The following is a description of a gene set: Interleukin-2 receptor (IL-2R) signaling is essential for T regulatory (Treg) cell development and homeostasis. Here we show that expression of IL-2Rbeta chains that lack tyrosine residues important for the association of the adaptor Shc and the transcription factor STAT5 in IL-2Rbeta-deficient mice resulted in production of a normal proportion of natural Treg cells that suppressed severe autoimmunity related with deficiency in IL-2 or IL-2R. These mutant IL-2Rbeta chains supported suboptimal and transient STAT5 activation that upregulate the transcription factor Foxp3 to normal amounts in natural, but not induced, Treg cells. Using cells T cell obtained from normal C57BL/6 mice and mice harboring Treg cells with impaired IL-2R signaling, gene expression profiling revealed many targets in peripheral natural Treg cells that were IL-2-dependent and a substantial overlap between the Treg cell IL-2-dependent gene program and the Treg cell transcriptional signature. Collectively, these findings demonstrate that a critical, and perhaps minor, subset of IL-2-dependent targets in Treg cells is indexed to a low IL-2R signaling threshold and that a substantial proportion of the Treg cell gene program is regulated by IL-2. CD4 T effector cells also showed many IL-2R-dependent gene and these also overlapped in a distintive manner with the IL-2-dependent genes of Treg cells and the Treg gene signature. Human Gene Set: GSE14350_IL2RB_KO_VS_WT_TREG_DN species: Homo sapiens Genes down-regulated in comparison of regulatory T cell (Treg) from IL2RB defficient mice versus regulatory T cell (Treg) from wild type animals. from publication Yu A, Zhu L, Altman NH, Malek TR (PMID 19185518), and this is the list of marker genes: PSTPIP2, TCN2, TMEM237, RRAGD, CBX6, TRPM4, HIPK2, ALOX15B, CKAP2, OSBPL3, CD83 (CD83 molecule), SLC7A10, F13A1 (NCBI Gene Id 2162), GSTO1, TF, TCF4, STXBP4, SH3RF1, ZNF516, NDRG1, LAMC1, ANXA4, ANKRD6, ICA1 (NCBI Gene Id 3382), ST3GAL5, CHSY1, HDAC9 (histone deacetylase 9), FCMR, NCF2, MIF4GD, C1orf116, SERPINE2, ANXA2, ZC3H12C, ELK3, DGKH, BCAS1, ZDHHC24, PRMT2, ADAMTSL4, GLCCI1 (NCBI Gene Id 113263, glucocorticoid induced 1), L1CAM, F2RL1, BASP1, APOBEC3B, SMOX, KLRG1, EPB41L4A, SLC15A3, SDHAF1, SSBP3, NSD2, EPHX1, MAPK12, LTB4R, S100A4, REPS1, MCUB, CCDC157, AS3MT, CD160, H1-0, SELENBP1, MKNK2, XDH, IFT80 (NCBI Gene Id 57560), YPEL2, CCN2, ARHGAP21, CD38, GPRASP2, SDC4, SELP, OAZ2, ZNF583, SESN1, NIBAN1, NTN4, HADH, ALCAM, CDKN2C, ABHD4, TRAF1, CSRP2, NT5E, GPR15, PRDM1, SERPINB6, LCLAT1, CD81, HECA, TNFRSF9, RGS9, GRB7, KCNK6, PHYHD1, FAM156A, DNAJC9, POLD3, PEX11A, PPM1L, IGFLR1, SLC39A4, PENK, ARMCX4, ZBTB32, TMBIM1, SLC16A3, MAN1C1, SRGAP3, CHCHD2, WLS, ADAM8, TAB2, ITGAE, MMADHC, SLC22A2, CTSW, DAPP1, RASIP1, PDCD1, PRR5L, EPCAM, TSPAN6, OBP2B (NCBI Gene Id 29989), PELI2, CDCP1 (CUB domain containing protein 1), MYO1F, SLC9B2, OMD, NDRG2, WDR35, CAPN3, IL1RL1, GTF2IRD1, KCNN4, TTC28, RAPH1, NAP1L3, TIFA, ATF6, TTC39C, ACADL, SMC6, NKG7, SLC16A14, MYO1E, SWAP70, TUBB2B, AXL, CCR6, ITSN1, STX8 (syntaxin 8), PIP5K1B, PLXDC2, HMGN3, TMEFF2, ADAMTS6, PLEK, MAGI3, PRG4 (proteoglycan 4), CXCL3, IKZF2, PPM1B, TWSG1, ECM1, SORL1, GPR83, FAM89A, AP3D1, CD1D, METTL8, CHST11, DAP, TBC1D14, PON3, CERK, POGK, FUT7, KY, CDSN, RAD51B, ZCCHC18, TSPOAP1, TMTC2, IKZF4, HLA-DOB, FAM72A, DNAJC12, ATP6V0E2, LGALS3, ENO3, PTPRJ, RHOQ, PTOV1, FAM234A, NSDHL, SAT1, UPP1, ZNF608